Given this list of marker genes Tyrobp, Grb2, Sftpd, here is a description of the gene set: studied in species Mus musculus part of: Cell-Cell communication electronically inferred by orthology from the curated human pathway This event has been computationally inferred from an event that has been demonstrated in another species.<p>The inference is based on the homology mapping from PANTHER. Briefly, reactions for which all involved PhysicalEntities (in input, output and catalyst) have a mapped orthologue/paralogue (for complexes at least 75% of components must have a mapping) are inferred to the other species. Reactome Pathway: Signal regulatory protein family interactions